Given this list of marker genes RAD1, RAD9A, HUS1, RAD9B, HUS1B, here is a description of the gene set: Human Gene Set: GOCC_CHECKPOINT_CLAMP_COMPLEX studied in species Homo sapiens Conserved heterotrimeric complex of PCNA-like proteins that is loaded onto DNA at sites of DNA damage.